Given this list of marker genes DHDDS, ALG5, ST3GAL6, AMDHD2, FPGT, PGM3, HK1, GLB1, FUOM (NCBI Gene Id 282969), ST3GAL2, GNE (glucosamine (UDP-N-acetyl)-2-epimerase/N-acetylmannosamine kinase), PMM1 (NCBI Gene Id 5372), NANP, NANS, NEU3, MVD, GMDS, ST3GAL3, ST8SIA3, NEU2, DPM1, ST8SIA4, ST6GALNAC5, SLC35A1, GMPPA, ST6GALNAC1, ST8SIA6, CTSA, ST3GAL5, ST6GAL1, DPM2, NUDT14, GFPT2, GFUS, RENBP, DOLPP1, FCSK, SLC35C1, DPM3, NAGK, ST6GALNAC2, SLC17A5, DOLK, NPL, GFPT1, ST6GALNAC3, ST8SIA5, ST8SIA2, NEU4, ST6GALNAC4, ST3GAL1, GMPPB, ST6GAL2, PMM2, CMAS, DHRSX, UAP1, MPI, NEU1, ST6GALNAC6, NUS1 (NUS1 dehydrodolichyl diphosphate synthase subunit), GNPNAT1, SRD5A3, ST8SIA1, ST3GAL4, here is a description of the gene set: Reactome Pathway: Synthesis of substrates in N-glycan biosythesis part of: Biosynthesis of the N-glycan precursor (dolichol lipid-linked oligosaccharide, LLO) and transfer to a nascent protein studied in species Homo sapiens Reactions for the synthesis of the small nucleotide-linked sugar substrates that are used in the synthesis of the N-glycan precursor and in the later steps of glycosylation are annotated here.<br>All these nucleotide-linked sugar donors are synthesized in the cytosol; however, to participate in the later reactions of N-glycan precursor biosynthesis (when the glycan is oriented toward the lumen of the endoplasmic reticulum (ER)), these substrates must be attached to a dolichyl-phosphate molecule and then flipped toward the luminal side of the ER, through a mechanism which is still not known but which involves a different protein than the one that mediates the flipping of the LLO itself. Two of the genes encoding enzymes involved in these reactions, MPI and PMM2, are known to be associated with Congenital Disorders of Glycosylation (CDG) diseases of type I. Of these, CDG-Ia, associated with defects in PMM2, is the most frequent CDG disease reported.